Given this list of marker genes PPIF, TNF, TRAP1, DNAJC15, ETFRF1, ACTN3, MLDHR, SNCA, RHOA, MIR210, MLXIPL, here is a description of the gene set: species: Homo sapiens Any process that stops, prevents or reduces the frequency, rate or extent of cellular respiration. Human Gene Set: GOBP_NEGATIVE_REGULATION_OF_CELLULAR_RESPIRATION